The following is a description of a gene set: species: Mus musculus The directed movement of substances, into, out of or within a cell, either in a vascular tissue or in the vascular membrane. Mouse Gene Set: GOBP_VASCULAR_TRANSPORT, and this is the list of marker genes: Gja1, Slc16a2, Flvcr2, Slc22a5, Apoe, Abcc2, Abcg2, Slc5a6, Slc27a1, Slc1a5 (NCBI Gene Id 269874), Abcg3, Mfsd2a, Slc5a1, Slc22a2, Lrp1, Abcb1a, Slc22a1, Abcc1, Abcb1b, Fabp5, Slc2a1, Ager, Slc27a4 (NCBI Gene Id 99453), Cd36